The following is a description of a gene set: Human Gene Set: GOBP_POSITIVE_REGULATION_OF_INSULIN_LIKE_GROWTH_FACTOR_RECEPTOR_SIGNALING_PATHWAY studied in species Homo sapiens Any process that increases the frequency, rate or extent of insulin-like growth factor receptor signaling., and this is the list of marker genes: AR, GHRH, PHIP, GHSR, IGFBP5, IGF1, CDH3, GH1, IGFBP3, WNT1, IGFBP4, MYORG, GHRHR